The following is a description of a gene set: species: Homo sapiens Genes down-regulated in follicular B lymphocytes: wildtype versus BCL6 knockout. Bcl6 germline deletion causes a prominent inflammatory disease, owing to over-expression of Th2 cytokines, and affects the properties of B cells prior to immunization. Therefore we established the B cell-specific Bcl6 deletion mice and analyze the gene expression of naive B cells under physiological conditions. Human Gene Set: GSE28737_WT_VS_BCL6_KO_FOLLICULAR_BCELL_DN from publication Kaji T, Ishige A, Hikida M, Taka J, Hijikata A, Kubo M, Nagashima T, Takahashi Y, Kurosaki T, Okada M, Ohara O, Rajewsky K, Takemori T (PMID 23027924), and this is the list of marker genes: RNF43, HEBP1, KIAA0825, PCP4, RBM27, RWDD2A, RBM38, PLAU, DUS3L, SLC2A3, PGGHG, GINS3, RIGI, LGALS8, SLC44A2, TNRC6B, GPR155, DNAJC28, G6PD, PREX1, BTRC, MED30, PXMP4, GUCD1, GALM, GSN, ASPM, HDAC8, NR4A1, ZNF383 (NCBI Gene Id 163087), PLXNC1, ELMO2, CD300LD (CD300 molecule like family member d), PPP1R14A (NCBI Gene Id 94274), LRRK1, MLH1, RAB21, CDKN1B, USP18, EDNRA, ROGDI, PDE7A, GCNT1, GOLGA7, ARHGAP9, RIN2, CST7, HLX, TMEM71, SPNS3, GABPA (NCBI Gene Id 2551), USP11, ZMAT3, HERC2, PRKCD, LAIR1, CD5, RGL1, MED13L, LTB4R, MKRN3, JAK1, NAIF1, PTPRJ, STK38L, DYNLT2B, CLEC4A, STAT5A, ARID5B, BPNT2, TSPAN2, MAPK8, TMEM81, SPATA13, DDX19A (DEAD-box helicase 19A), CDC23, FAM98A, LBR, HDC, ZWINT, MMP12, SLC25A35, EML3, UBE2B, G6PC2, PWWP3B, TRIM36, RCAN3, TAF1B, TESC, STARD9, PIK3AP1 (phosphoinositide-3-kinase adaptor protein 1), ZNF414, SNX14, TBC1D4, ARHGAP25, RNF122, S100A4, CCND2, ACKR1, SLC7A7, ARHGEF3, CCNE1, ZSWIM1, UNC5CL, NRBF2, OSBPL5, KANSL3, CADM3, STAU2, LUM, SNX10, PLTP, KRT80, XXYLT1, SLC49A4, SPIDR, GTPBP3, POLR2B, EID2, ZHX2, ABHD4, STK32C, LIMD2, HDAC10, HELQ, PIK3CG, DNAJB4, TNFRSF11A, HUS1, RELB, MID1, TMEM45B, B4GALT1, CMTR1, CTSD, PFN2, TRAF7, RPA2, CAPSL, SCN2B, RPRD1B, PAK1IP1, MTAP (methylthioadenosine phosphorylase), CD244 (NCBI Gene Id 51744), ZNF418, MREG, CRLF3, TRAF3IP1, HECTD2, CDH17, TOP2A, PRKDC, CAPZA2, PLA2G7, DUSP22, RABEP1, LMNB1, ERRFI1, FDFT1, FBXO25, TTLL5, CHMP1A, AVPI1, GMFG, TNFRSF13B, P2RY13, RHOF, C1orf159, MYO1E, TUBGCP6, NHSL2, SLC2A6, SNX20, PCYT1A, FASLG, DAPP1, DHRS3, TMEM273, SLC12A2, POR, SH3BGRL, ADAMDEC1, RNF34 (NCBI Gene Id 96268), CCNF, RELT (RELT TNF receptor), NTPCR, ACAP1, TMEM106B, ST3GAL2, KATNAL2, CD4, ZNF653, SGK3, DNAJA2, DIAPH3, SMIM3, GPM6B, E2F2, PRDM1